The following is a description of a gene set: Mouse Gene Set: MIR_7236_3P from publication Chen Y, Wang X (PMID 31504780) species: Mus musculus Genes predicted to be targets of miRBase v22 microRNA mmu_miR_7236_3p in miRDB v6.0 with MirTarget v4 prediction scores > 80 (high confidence targets)., and this is the list of marker genes: Golph3, Sacm1l, Padi2, Crebrf, Sult6b1, Dhx33